The following is a description of a gene set: Genes predicted to be targets of miRBase v22 microRNA hsa-miR-3619-5p in miRDB v6.0 with MirTarget v4 prediction scores > 80 (high confidence targets). Human Gene Set: MIR3619_5P from publication Chen Y, Wang X (PMID 31504780) species: Homo sapiens, and this is the list of marker genes: ERC1, LUZP1, FNDC5, LARP1, KCNH8, SLC13A3, EDF1, ATP2A3, USP46, C1orf226, CNIH1, GDNF, INO80C, FBLN5, HSD17B8, MAP3K4, ATP8B2, CEP44, BCL2L11, NAA50, ACSL1, BTAF1, TMEM43, ARF4, RCSD1, PID1, RAB4B, TSPAN11, HIP1, BAX, ATG16L1, MTA3, ACVRL1, GALNT18, KRTAP2-2, PRR14L, SLC8A1, TNPO1, DHRS12, FGFR1, NMB, JPH1, ARHGAP26, TMEM161B, PLAGL2, RBM20, SPPL3, ZFHX3, SLC23A2, SDAD1, CTNNB1, MOBP, HPSE2, KBTBD2, CPSF4, SNX8, RGS22, PHF21A, NFIA, IRS1, PGF, MFN2 (mitofusin 2), KRTAP10-4, RIPOR2, MED19, PHF20L1, MLXIP, F8, HMGN4, DPP8, TUT4, MTCL2, AMMECR1L, PPP2CB, PURB, FBXO32, GPN1 (GPN-loop GTPase 1), STK32B, HMGN3, SORBS1, CHD2, NEURL1B, UBE4A, SIGMAR1, ATP8A1, AKAP13, PYM1, ZNF641, USP30, GLOD5, NFATC2, SIK2, ADSS2, EXOC3L2, KIF21B, NUFIP2 (NCBI Gene Id 57532), TRABD2B, YWHAZ (tyrosine 3-monooxygenase/tryptophan 5-monooxygenase activation protein zeta), BTBD1 (NCBI Gene Id 55029), PDLIM5, RNF169, DMXL2, PCDH20, MTMR3, TMEM248, RBM34, MAPK8, ARID3B, PLXDC1, RHPN1, BAZ2A, PAN2, PIM1, PIK3CB, GSK3B, IPO11, HR, CXXC5, CLSTN1, RPUSD1, RC3H1, COG5, KCNC2, MTM1, C17orf49, DUSP15, FGF14, IPO7, RPIA, CMTM4, ZNF710, VSTM4 (NCBI Gene Id 196740), TAFA4, CPEB1, SOS2, KCNC4, LTF, KRTAP4-4, PHACTR3, TRA2B, GCC2, ALPK2, FAM135B, MPI, OPRK1, MYO1D, PLA2G3, CELF1, PARP16, TMEM33, DBNDD1, UTS2B, BRPF3, CBX2, LHX6, CBR4, SOX8, ERFE, JAKMIP2, PPM1L, GARRE1, NPTXR, ZFAND3, IGSF3, SPTBN2, RAB14, MAK16, PRICKLE2, WDTC1, USP24, IKBKB, ATP6V0E2, SEC31A, PDE11A, PDE5A, PGGT1B, DOLPP1, PRRC2B, TFAP2C, UBL4B, SCAMP4, TGIF2, MAPK1 (NCBI Gene Id 5594), VPS53, NOMO3, ST6GALNAC1, DAPK2, ZBTB20 (zinc finger and BTB domain containing 20), TRAF1, SMARCC1, GATD3 (NCBI Gene Id 8210), KIF13A, HMG20A, PRR23B, NSD1, PROX1, ERRFI1 (ERBB receptor feedback inhibitor 1), GPR6, CLASP1, CBL, TGOLN2, PTER, ZBTB39, TANC2 (NCBI Gene Id 80259), RAP1GAP2, CERT1, SNX12, EXOC2, DLL1, ALS2, MMS19, SLC25A25, RALGAPB, UHMK1, CPEB4, KSR1, VANGL2, QKI, COP1, KIF7, TBL1XR1, CREBL2, SLC25A39, NEO1, CTSS, DAGLA, MLLT10, PELI3, ITGB8, FAM20B, CRKL, CAPN11, OXR1, CSF1, ZBTB10, GPR85, ZNF609, RIMS3, GNAL, DBNDD2, BCL11A, TRAF3, MBLAC2, USP3, USP20, KMT5A, MECOM, IL17RD, SLC36A1, PHF6, UBE2R2, FAM110D, GALNT7, KPNA1, LSM12, CENPM, LRP2, PCMT1, PPP6C, TMEM86A, NAA15, ARL2, SMYD5, RAPGEFL1, SEC24C, SYT15 (NCBI Gene Id 83849), GFRA1, SARM1, PCLO, RUBCN, CCDC103, TAOK1, SLC25A42, ZNF214, MEAF6